Given this list of marker genes OST4, NDUFB8, PFDN2, RPS21, NHP2, NEDD8, ATP5F1E, RPS29, NDUFS6, NDUFA1, COX17, RPL21, TMEM258, SEM1, NDUFA12, NDUFB1, SNRPG, COA3 (NCBI Gene Id 28958), UQCR10, NDUFAB1, NOP10, ATP5MK, LGALS1, NDUFB2, SNRPD2, SLIRP, SEC61G, TIMM8B, ATP5MF, NDUFA3, COPS9, COX6B1, ROMO1, LSM7, APRT, UBL5, ATOX1, H3-3A, SNRPF, ATP5ME, ATP5MC1, NDUFA7, NME1, COX7B, PSMB3, NDUFC1 (NCBI Gene Id 4717), PET100, NDUFS5, NDUFB4, here is a description of the gene set: studied in species Homo sapiens In this study, an extensive analysis was conducted to define meta-programs (MPs) capturing intra-tumor heterogeneity across a spectrum of tumor types. The approach utilized non-negative matrix factorization (NMF) to analyze each cell type separately within individual tumor samples. This involved the analysis of malignant cells, macrophages, fibroblasts, endothelial cells, epithelial cells, T-cells, and B-cells. NMF was executed with varying parameter values (K=4, 5, 6, 7, 8, 9), thereby generating 39 programs for each cell type per sample. Each NMF program was summarized by the top genes based on NMF coefficients.\nRobust MPs were then delineated for each cell type using a set of stringent criteria, including recurrence within the same tumor, similarity to programs in other tumors, and non-redundancy within a tumor. Subsequently, these robust NMF programs were clustered (per cell type) based on Jaccard similarity, leading to the identification of MPs associated with each cell type.\nTo enhance the quality of the MPs, a refinement steps were undertaken, involving the removal of MPs suspected of reflecting low-quality data (with an overrepresentation of ribosomal proteins or mitochondrial-encoded genes), single-study inclusion, or similarity to miss-annotated cell types. Genes upregulated in subsets of cells of a given type within various tumors Human Gene Set: GAVISH_3CA_MALIGNANT_METAPROGRAM_21_RESPIRATION from publication Gavish A, Tyler M, Greenwald AC, Hoefflin R, Simkin D, Tschernichovsky R, Galili Darnell N, Somech E, Barbolin C, Antman T, Kovarsky D, Barrett T, Gonzalez Castro LN, Halder D, Chanoch-Myers R, Laffy J, Mints M, Wider A, Tal R, Spitzer A, Hara T, Raitses-Gurevich M, Stossel C, Golan T, Tirosh A, Suvà ML, Puram SV, Tirosh I (PMID 37258682)